Given this list of marker genes Rabggtb, Fntb, Pggt1b, Fnta, Ptar1, Rabggta, here is a description of the gene set: Mouse Gene Set: GOMF_PROTEIN_PRENYLTRANSFERASE_ACTIVITY studied in species Mus musculus Catalysis of the covalent addition of an isoprenoid group such as a farnesyl or geranylgeranyl group via thioether linkages to a cysteine residue in a protein.